The following is a description of a gene set: Human Gene Set: REACTOME_NITRIC_OXIDE_STIMULATES_GUANYLATE_CYCLASE species: Homo sapiens Nitric oxide stimulates guanylate cyclase, and this is the list of marker genes: PDE1A, PDE1B, PDE9A, NOS1, PDE5A, GUCY1B1, KCNMB4 (potassium calcium-activated channel subfamily M regulatory beta subunit 4), NOS3, NOS2, PDE11A, KCNMB3, PRKG2, PDE10A, GUCY1A1 (guanylate cyclase 1 soluble subunit alpha 1), KCNMB2 (potassium calcium-activated channel subfamily M regulatory beta subunit 2), KCNMA1, IRAG1, GUCY1A2, KCNMB1, ITPR1, PDE2A, PRKG1